The following is a description of a gene set: species: Mus musculus Mouse Gene Set: GOBP_REGULATION_OF_RESPIRATORY_GASEOUS_EXCHANGE_BY_NERVOUS_SYSTEM_PROCESS A process carried out by the nervous system that is required for the proper control of respiratory gaseous exchange. This process occurs in the respiratory center of the brain in vertebrates., and this is the list of marker genes: Pbx3, Adora1, Mecp2, Gsx2, Glra1, Tlx3, Cc2d1a, Nlgn1, Gls (NCBI Gene Id 98298), Atp1a2 (ATPase, Na+/K+ transporting, alpha 2 polypeptide), Tshz3, Nlgn2, Nlgn3, Phox2b